Given this list of marker genes GSTP1, MGST3, GSTM3, GSTM4, GSTA4, GPX3, GCLM, GCLC, GSTT1, IDH1, GSTA3, GPX1, GPX2, GSTZ1, GSTM1, GSR, NCF1C, GSTM5, GGT1, GSTM2, MGST2, GSTA2, here is a description of the gene set: ROS metabolism. studied in species Homo sapiens Human Gene Set: MODULE_310